Given this list of marker genes ITPR1, SNAI1, ASXL1, AMBP, GIT1, MIR1-1, ABHD17A, TRIB1, ARRB2, SKA3, ASH1L, NHERF4, TRIM67, RRM2B, DUSP7, TGIF1 (TGFB induced factor homeobox 1), HEG1, SAMTOR, MIR223, MAP2K1, PRAP1, MAPKAP1, DKK1, TCF7L2, SESN1, DEFB114, PSMD10, MFN2, RELA, CRYBA1, LIMD1 (NCBI Gene Id 8994), CYP26B1, NOL3, PARK7, MARCHF5 (NCBI Gene Id 54708), LDLRAD4, EID2, MAPK3, MIR483, ARHGAP17, VPS18, CLOCK, CD2AP, ACE2, STUB1, PTPRR, PRKAR2B, ATXN3, ENO1, RGS14, COMMD1, ZNRF4, DDIT4 (DNA damage inducible transcript 4), ITGB1BP1, SYVN1, DUSP2, HIF1A, MIR34B, CPTP, CRY2, RNF39, DNAJA3, CCAR2, NLRP2B, CCDC125, KPTN, RNF125, SKI, TAX1BP1, SPRY2, NPPA, CARD19, EPO, SIRT2, ZNF366, PTPN1, PPM1A, RNF34, HMGA2, NR1D1, MIR185, RACK1, TAF9, KCTD10, MIR26B, TNFAIP8L1, FGF2, PRKN, AKT2, PPEF2, STAT3, THEM4, MIR195, C1QTNF3, PRKACA, PRKDC, TBC1D10C, HTRA2, CTNNB1, LYPLAL1, SZT2, CASTOR2, NUP62 (NCBI Gene Id 51551), MIR26A1, AIDA, PDE3A, USP7, GRINA, USP47, INSIG2, MAD1L1, TLE1, WNK1, MAP2K3, SLC24A4, CYRIB, SEC14L1, CDKN2D, ACKR3, WNT1, NPRL2, SEMA6A, C3orf33, MAPK7, KLF4, RAB7B, SIVA1, CCDC22, TXNDC12, MIR9-1, CTNND1, BCL6, BRCA1, TMEM161A, DLG5, GSK3B, WNK2, PDE10A, UBR2, DUSP10, PRKAR1A, PREX2, SH2B3, P2RX7, MIR27A, CHRNA7, OTUD7B, HLA-G, SIRT3, PPARG, MIR206, MYOZ1, HSPA1A, MIR92B, PKIA, ZDHHC18, SFRP2, MAPK14, TSC1, PRKAA1, MUL1, DUSP26, CGNL1, NLRP3, DEPDC5, MIR132, DSG3, NFKBIA, EPM2A, UBE2N, SMPD3, KLHL31, PKHD1, MIR766, PIN1, NF1, PELI1, CYP7B1, ATAD3A, SH3BP4, PDCD4, NPLOC4, LBH, FZD1, TSC2, INPP5E, PPT1, TRIM65, CGAS, WTIP, SMAD4, ACTN3, SLA2, SLIT2, USP49, BDKRB2, BCL2, PDE2A, APOE, IRAK1, MIR149, PRMT1, TMBIM6, RGS2, DHX58, CYP26C1, RPS6KB1, NME5, CASTOR1, TP63, DYRK1A, PP2D1, BMP7, FOXM1, TLR4, PYCARD, IGF1, QARS1, DAG1 (NCBI Gene Id 1605), BANK1, EGLN1, KDM1A, VRK3, DUSP13B, SERPINE2, MINAR1, SLC8A1, DDIT3, RIPOR2, NFKBIL1, FBP1, FBXW7, MSTN, SPI1, STK11, SIRPA, CNOT2, FOXH1, HDAC7, CIB1, STMN3, NCOR2, CALR, CAVIN3, DUSP4, SYNGAP1, SPRED3, MIR146A, DUSP6, USP10, RASAL1, CD200, MAP3K20, IRGM, ARHGAP45, RNF149, KICS2, NR0B1, CDK5RAP3, INS, NPRL3, LAMP2 (lysosomal associated membrane protein 2), MIR29A (NCBI Gene Id 407021), ITGA3 (integrin subunit alpha 3), ABHD8, IKBKG, MYC, MIOS, MORN3, GPX1, CASP8, CD74, UACA (uveal autoantigen with coiled-coil domains and ankyrin repeats), LILRA4, MIR23A, NCOR1, MARCHF7, DUSP8, TWIST1, TKFC, HEYL, KCTD13, TAF3, MIR508 (microRNA 508), IVNS1ABP, MIR138-1, ARHGAP22, SPSB3 (NCBI Gene Id 90864), LZTR1, DDX3X, MIR16-1, NF2, PTPN22, DLC1, NPC1, ITFG2, YJU2, TANK, MIR145, WDR59, ARHGAP29 (Rho GTPase activating protein 29), VEPH1, CNOT1, PTPN6, SERPINB3, MKRN2, PMEPA1, RORA, CHP1, MIR140, PRAME, DACT1, NCK1, DUSP29, CSK, PRKCD, MIR29C, ARHGEF2, GBA1, AJUBA, MAGEA3, TRIM32, MARK3, MIR503, UBE3A, PPP6C, PTGS2, STMN1, MIR323A, RNF152, BMAL1, SFRP1, PRKAR2A, STRIP1, INSIG1, BANF1, HUWE1, SIRT1, HELLS, TNFAIP3, EPHA7, ARMC10, ARHGAP30 (Rho GTPase activating protein 30), RANBP9, PHLPP1, SPRED1, PTTG1IP, DUSP3, PTPN2, LOX, STK38, MIR133B, CHRNA9, NKIRAS1, FBXL2, MIR200C, TRIAP1, CYP26A1, INPP5K, MIR34C, PPIF, RPS6KA1, VHL, LITAF, PIK3R2, PCBP2, NLK, EIF3A, SAR1A, SIRT7, ZBTB7A, CDK12, NLRC3, MIR30C2, SPRED2, MIR449A, YWHAZ, NOG, MAPKBP1, F2RL1, TREX1, UBE2W, TMC8, EDN1, PHB1, PEBP1, PINK1, MARVELD3, NHERF1, OGT, FHL2, UFL1, MTM1, STRN3, GSK3A, OVOL2, SEC13, PDX1, TNIP2, ADIPOQ, WDR91, DDIAS, WWC1, TNIP1, SIKE1, BTN2A2, NODAL, TLR9, DUSP5, EPHB2, NCK2, NLRX1, ATXN3L, PARL, FOXP1, MLXIPL, CUL3, GPS2, CD300A, SHANK2, RIPK1, NMI, PIK3CB, MEFV, CILP (cartilage intermediate layer protein), FLCN, CLU, RUBCN, STRN4, ABL1, SH3RF2, LIF, INPP5A, PTPRJ, WWC3, HOMER2, DNAJA1, OPA1, PRKAA2, PYDC2, LPAR1, TGFBR3, DAB2, FIGNL1, RASA4 (RAS p21 protein activator 4), TRIM60, MTNR1B, PYCR1, TCF21, BCL2L12, FKBP1B, MIR130A, IGBP1, ABL2, MIR15A, SFRP5, EPHA4, PARP1, OTUD3, GPATCH3, DDRGK1, PAQR3, SLC8A3, RASAL3, MDM2, CRKL, CIT, FAM89B, RASA4B, YBX3, SMAD7, DHRS3, MIR21, UCHL1, PPM1B, ATAD5, KANK2, TBK1, STYXL2, MAD2L1BP, ARHGAP12, ATF6B, AZI2, PDCD6 (programmed cell death 6), LAX1, DAB2IP, PREX1, TBX20, CHRNA10, CRY1, CXCL12, FAF1, GSTP1, ITGB1, USP20, CHEK2, VGLL4, IGF1R, CD22, UFD1, NLRP12, OLFM4, NR1H4, SOD2, LRP1, CASTOR3P (NCBI Gene Id 352954), NFE2L2 (NFE2 like bZIP transcription factor 2), HACD3, CREB3, PPP1R15A (NCBI Gene Id 23645), SMPD1, RHOA, MAPK8IP1, SMAD6, ARHGAP24, DUSP19, PRDM15, ENG, ING2, GDF15, DGKG, PPIA, MIR19A, SNIP1, EMILIN1, MIR34A, SLMAP, HSPB1, FKTN, SYNJ2BP, WDR24, TRIM15, PTEN, HDAC3, PPP1R15B, TRIM11 (NCBI Gene Id 81559), MIR885, AGT, GPER1, GREM1, CNKSR3, TMEM127, DUSP1, MIR29B1, MIR27B, SNAI2, IL10, GRAMD4, FBXO7, BRD4, TNFAIP1, RABGEF1, SH3GL2, WWC2, C1QBP, RRN3, MIR17, TRIM59, FOXO1, TMSB4X, HIPK3, TREM2, CBLC, ARHGAP42, SESN2, C1QL4, PHLDA3, GMIP, ZC3H12A, SRC (NCBI Gene Id 6714), BCL2L1, AIM2, AKT3, ATF4, MUC1, ATM, TAOK3, PTPRS (protein tyrosine phosphatase receptor type S), PTPRC, CD44, ATF3, CREB3L1, UBQLN1, ATP2B4, PPP2CB, MIRLET7G, UBE2D1, DGKD, SPAAR, XBP1, FBLN1, ARHGAP44, RIOK3, SLC39A8, PIP5KL1, MIR424 (microRNA 424), DLG1, CCN3, SH3BP1, NLRP6 (NLR family pyrin domain containing 6), IFI16, ERBIN, AARS2, ANXA4, LEMD2, MIR497, TGFB2, EZR, SEH1L, TRAP1, MAPKAPK5, PPP5C, DNAJB9, MIR92A1, ADIPOR1, YWHAG, RASGRF1, RASIP1, ESR1, TBC1D7, ITCH, TRIM39, NLRP2, DUSP16, AKT1, TARBP2, RNF167, PAFAH1B1 (NCBI Gene Id 5048), UBR1, SPRY4, LRRK2, EZH2 (NCBI Gene Id 392834), RASA3, VPS11, THBS1, AURKB, DYRK2, PRKACB, MOB4, TAF9B, MEN1, MECOM, NOC2L, PLEK, RHOH, RPS6KA6, BFAR, RTKN2, MIR4691, PLK3, MIRLET7F1 (NCBI Gene Id 406888), TRIM40, FOXJ1, CYLD, PLAUR, MIF, PRNP, CACTIN, IRAK3, STAMBP, NKIRAS2, CREBRF, PRKAR1B, MYOZ2, PIAS4, CAV3, TPT1, AKT1S1, HYAL2, FNIP1, HERPUD1, DRD3, ENDOG, GATA4, BAG5, MTOR, PLIN5, SMPDL3A, DEPTOR, KANK1, ADGRG3 (adhesion G protein-coupled receptor G3), MIR375, RCAN1, CARD8, MIR15B, MIR204, CSNK1A1, UCMA, ISL1, LILRB4 (NCBI Gene Id 11006), SELENOS, PBK, IFI35, TRIM31, SPRY3, RASA2, MIR20A, RASSF2, HSPA5, PER1, NPY2R, NDRG2, PLEKHA1, MIR101-1, SAR1B, SBNO1, PIK3IP1, TRIB3, SESN3, ABCA7, APLNR, RFFL, PPP2CA, SMARCA4, ERRFI1, ZNF675, AARS1, PYDC5, LMO3, HAPSTR1 (NCBI Gene Id 29035), URI1, HDAC1, DYRK3, ARHGAP35, HYOU1, MIR365A, BID, MIR133A1, SPINK1, PPP1R10 (NCBI Gene Id 5514), NONO, CPNE1, DUSP9, TAF1, RIPOR1, CSNK2A1, PPARA, SKA1, CNOT9, MIR218-1, FYN, STAT1, MIR221, WFS1, ELL3, PPP2R1A, NDUFC2, MYOC (NCBI Gene Id 4653), DRD2, PSCA, MIR205, ZNF536, LYN, OPTN, SCAI, VCP, MMP9, NOP53, PHB2, CAV1, HOMER3, HSPA8, TNIP3, IL1B, IRAK2, GBP1, PDE11A, ZMYND11, ZNF385A, MET, MIR199A1, TSPAN6, ZDHHC12, MAP2K5, MMP3, SPRY1, PIAS2, PYDC1, ARHGAP25, MAGI2, EFNA1, here is a description of the gene set: species: Homo sapiens Human Gene Set: GOBP_NEGATIVE_REGULATION_OF_INTRACELLULAR_SIGNAL_TRANSDUCTION Any process that stops, prevents or reduces the frequency, rate or extent of intracellular signal transduction.